Given this list of marker genes Maip1, Bcs1l (BCS1 homolog, ubiquinol-cytochrome c reductase complex chaperone), Oxa1l, Slc12a1, Cox18, Tmem126a, here is a description of the gene set: Mouse Gene Set: GOBP_PROTEIN_INSERTION_INTO_MEMBRANE_FROM_INNER_SIDE species: Mus musculus The process in which a protein is incorporated into a lipid bilayer, e.g., the prokaryotic, mitochondrial, or chloroplast inner membrane, from the inner side.